The following is a description of a gene set: Mouse Gene Set: CUI_TREG_TNFA_RESPONSE_DN Cytokines mediate cell-cell communication in the immune system and represent important therapeutic targets. A myriad of studies have highlighted their central role in immune function, yet we lack a global view of the cellular responses of each immune cell type to each cytokine. To address this gap, the authors created the Immune Dictionary, a compendium of single-cell transcriptomic profiles of more than 17 immune cell types in response to each of 86 cytokines (>1,400 cytokine-cell type combinations) in mouse lymph nodes in vivo. A cytokine-centric view of the dictionary revealed that most cytokines induce highly cell-type-specific responses. For example, the inflammatory cytokine interleukin-1β induces distinct gene programmes in almost every cell type. A cell-type-centric view of the dictionary identified more than 66 cytokine-driven cellular polarization states across immune cell types, including previously uncharacterized states such as an interleukin-18-induced polyfunctional natural killer cell state. from publication Cui A, Huang T, Li S, Ma A, Pérez JL, Sander C, Keskin DB, Wu CJ, Fraenkel E, Hacohen N (PMID 38057668) species: Mus musculus Genes negatively differentially expressed in cell type: Treg upon treatment with cytokine: TNF-α in mouse lymph nodes in vivo., and this is the list of marker genes: Arhgdib, Jun (jun proto-oncogene), Rhoh, Nt5e, Ift80, Klf2, Emp3, Ahnak, Klf6, Ms4a4b (NCBI Gene Id 60361), Tmem50a, Nrp1, Id3, Izumo1r, Tnik (TRAF2 and NCK interacting kinase, NCBI Gene Id 99639), Ptprc, Cd3g, Ipcef1, Tsc22d4, Ypel3, H1f4, S100a6, Ephx1, Dgkz, Smpdl3a, Capg, Macf1, Slamf6, Cmah, Icos, Ankrd44, Cd28, Itgb7, Vim, Fos, Mbnl1, Evl, Rgs10 (NCBI Gene Id 67865), Hspa1a (NCBI Gene Id 193740), Ptprcap, Akap13, Arhgap45, Itm2b, Top2b, Stap1, Cdkn1b, St8sia4, Maf, Tespa1, Ramp1, Hspa1b, Trbc2, Trbc1, Fxyd5, Crip1, Mxd4, Ms4a6b, Nav2, Stk17b, Btg2, H1f2, S100a10